The following is a description of a gene set: from publication Chen Y, Wang X (PMID 31504780) Human Gene Set: MIR5093 studied in species Homo sapiens Genes predicted to be targets of miRBase v22 microRNA hsa-miR-5093 in miRDB v6.0 with MirTarget v4 prediction scores > 80 (high confidence targets)., and this is the list of marker genes: UBR3, ADAMTS6, UBTD2, SPTLC2, SLC27A2, TRPC1, PTPRT, NDFIP2, FUT9, VDAC2 (voltage dependent anion channel 2, NCBI Gene Id 7417), WAC, TRABD2A, GOLT1B, ING3, SCGB2A1, GPR155, MICAL2, SGO1, PLCXD3, ZFYVE28, DAP, CD109, USP49, ARIH2OS, LMX1A, TMA16, CMPK1, FNBP1L, SOST, SAMD4A, BNIP2, RNF8, SLC2A12, KAT6A, AK1, CHIC1, STK3, LRATD2, SELENOI, UBE2QL1 (ubiquitin conjugating enzyme E2 QL1), USF3, PGR, DNALI1 (dynein axonemal light intermediate chain 1), RC3H1, NECTIN2, B3GALNT2, PCNP, DUOX2, LYSET, MCFD2, RTN2, KLF11, MAP3K2, HNRNPAB, ATP13A3, LAMA1, MAP3K7CL, KIFAP3, MOB3B, RNF180, BMPR2, GRIN2A (glutamate ionotropic receptor NMDA type subunit 2A), MYCT1, TAFA2, UMAD1, BOLA3, OSBPL3, CHD1, SKIL (NCBI Gene Id 6498), TCF20, ZBTB20, F2RL2, DKK2, CETN2, SLCO5A1, CCDC88A (NCBI Gene Id 731560), RIMBP2, POU2F1, SPACA9, SAMD5, SORBS3, MIA3, UBE2D2, NTRK2, MFSD14A, TFDP2, PRKG2, SBF2, SLC4A7, ZNF333, ABHD18, NR6A1, TMPRSS11E, PPIP5K2, PUM1, ELL2, JAKMIP2, NDST1, CDC42SE2, CYP26A1, TIMP3, PSMA5, DCDC1, FAM169A, ENC1, GTF3C4, ZNF527, PHIP, SNAP25, RANBP3L, CCR1, KIF13B, GAS1, IRS1, PTPN14, CYP21A2, ATP6V1G1, SHROOM3, PCBP2, USP3, RGS8, SRBD1 (S1 RNA binding domain 1), RPGR (NCBI Gene Id 6110), TMEM220, FAT1, RBM42, ARB2A, HFE, MYEF2, MAIP1, CYFIP2, FKBP5, SMARCAD1, NIPSNAP3B, NRN1, VTCN1, APOLD1, ZBTB21, ZRANB2, KCMF1 (NCBI Gene Id 57734), NR3C1, NBPF15, AGO4, HSPA4L, SREK1, ZBTB39, RAB30, PCDHB15, ZC3H12C, SERPINB13, SLC22A4, ATAT1, TUBGCP5, LRRC8D (NCBI Gene Id 55144), RPTN, ZNF704, SNTB2, KLF6, LRRC27, PIK3C2A, MSANTD2, SELENOP, PPAT, UBE2A, CHST11, ZNF750, KCNA3, COL5A2, POLR1E, ITPRIPL2, CBL, HDX, SLC1A3, SH3YL1, LANCL1, NIPA1, WBP11, GNAQ, SLC25A21, AIFM2, MAPKAPK5, GMEB1, CASD1, WNK1, TSHZ2, OPRM1, RBFOX2, EXOC6B, RBM39 (NCBI Gene Id 9584), TINAG, SERBP1, NCOA1, ST13, CFTR, CALB1, SSBP1, SLCO2B1, RBM47, ACSL1, HIVEP2 (HIVEP zinc finger 2), C2orf68, NAA50, FAM117B, MPZ, MLXIP, SEMA4G, SLC18B1, IKZF1, DBT, CPNE4, MOB1B, PABPN1, PDZD8, RTKN2, TXLNG, FIGN, CRYBG1, SLC17A6, ST3GAL1, EML5, DOK3, ZNF624, CNGB1, CAMK2D, CCDC6, MYLK4, ABHD17C (abhydrolase domain containing 17C, depalmitoylase), GRIA2, RLBP1, AAK1, NET1, LRP12, CIDEB, LHX6, RIMKLA, LONP2, GPR161, VEGFC, PHYHIPL (phytanoyl-CoA 2-hydroxylase interacting protein like), IRF8, SMURF2, YPEL5, KRT31, SETBP1